The following is a description of a gene set: studied in species Homo sapiens Human Gene Set: GOBP_CELL_CELL_SIGNALING_INVOLVED_IN_CARDIAC_CONDUCTION Any process that mediates the transfer of information from one cell to another and contributes to the heart process that regulates cardiac muscle contraction; beginning with the generation of an action potential in the sinoatrial node and ending with regulation of contraction of the myocardium., and this is the list of marker genes: SCN1B, GJA5, TRPM4, HCN1, SCN4B, ANK2, GJA1, CACNA1G, KCNQ1, SCN10A, CACNA1C (calcium voltage-gated channel subunit alpha1 C), CACNA1D, KCNJ5, NUP155, CXADR, SCN5A, RYR2, KCNA5, CACNA2D1, TBX18, KCNJ3, GJC1, HCN4, RANGRF (RAN guanine nucleotide release factor), CACNB2 (NCBI Gene Id 783), FLNA, KCNE5, KCNN2, MIR208A, HCN3, CASQ2, MIR328, SCN3B